Given this list of marker genes SP1 (NCBI Gene Id 6667), TRIM23, DIPK1A, PRKD1, MYO1F, ARG2, PTBP2 (NCBI Gene Id 58155), CACUL1, SLC15A5, PDE7A, MYH1, CRIPT, SLC19A3, ZBED10P, RAB14, BEND2, TAFA1, CSNK1G3, PFKFB2, LZTS2, BBX, CSRNP1, ABCC1, AGL, RNF146, UBXN7, EFNB3, PIK3CB, NKAPL, MTMR8, PCDH17, P2RY2, ZDHHC15, AKIRIN1, RAB21, IDH1, RAB27B, LDLRAP1, FAF2, YIPF4, DYNC1LI2, CDK8, SCOC, DYNLT3, ATG3, ZNF326, NUS1, SMARCA2, NIPAL4 (NIPA like domain containing 4), RETNLB, NSF, MAN1A2, TBL1X, CACNA1B, PHTF2 (putative homeodomain transcription factor 2), COL1A1, SGSM1, DGCR8, PPP6R3, NPAT, RSF1, CCN2, RC3H2, DNAH5, ANK2, TRAF3, CELF2, COL25A1 (collagen type XXV alpha 1 chain), TTPAL, PRDM1, C11orf58, CPNE3, CXCL12, MARS2, HIPK3, TNFSF10, NR6A1, ACER3, RALGAPB, ATRX, G3BP2, GLP1R, GLS, KMO, ZDHHC7 (NCBI Gene Id 55625), ROCK2, MAP3K5, SMAD5, PHF6, FDXACB1, FGFR1, NSMF, TGDS, LRRC40, ZHX1, PCDHB13, CAND1, ADAMTS5, HS3ST5, DPH5, TMED10, ELOVL1, UGCG, SPRED1, TCF12, CD2AP, CD93, HIVEP1, RBM4B (RNA binding motif protein 4B), AP2M1, GABRG3, SMAD1, here is a description of the gene set: Genes predicted to be targets of miRBase v22 microRNA hsa-miR-5587-5p in miRDB v6.0 with MirTarget v4 prediction scores > 80 (high confidence targets). studied in species Homo sapiens from publication Chen Y, Wang X (PMID 31504780) Human Gene Set: MIR5587_5P